The following is a description of a gene set: studied in species Homo sapiens from publication Hay SB, Ferchen K, Chetal K, Grimes HL, Salomonis N (PMID 30243574) Human Gene Set: HAY_BONE_MARROW_PRE_DENDRITIC, and this is the list of marker genes: AREG, SAMHD1, AXL, CTSV, SPATS2L